The following is a description of a gene set: studied in species Mus musculus Mouse Gene Set: GOBP_STEROID_HORMONE_BIOSYNTHETIC_PROCESS The chemical reactions and pathways resulting in the formation of any steroid hormone, naturally occurring substances secreted by specialized cells that affects the metabolism or behavior of other cells possessing functional receptors for the hormone., and this is the list of marker genes: Hsd3b3, Hsd3b6, Hsd17b12, Rest, Scp2, Med1, Egr1, Nr5a2, Srd5a1, Hsd3b1, Bmp5, Gm2044, Cacna1h, Srd5a2, Dhrs11, Akr1c14, Cyp11b1, Wnt4, Nr3c1, Hsd17b7 (hydroxysteroid (17-beta) dehydrogenase 7), Hsd17b3, Ppargc1a, Hsd3b2, H6pd, Scarb1, Cyp19a1, Star, Cyp17a1, Hsd11b1, Hsd17b2, Cyp11b2, Hsd17b1, Dab2, Clcn2, Dkk3, Hsd17b8, Cyp27a1 (NCBI Gene Id 74768), Dgkq, Bmp2, Crh, Bmpr1b, Atp1a1, Stard3, Cyp21a1, Cyp11a1, Bmp6